Given this list of marker genes MSMO1, EBP, HSD17B7, GGPS1, SREBF1, HMGCR, DHCR7, LBR, LSS, DHCR24, PLPP6, ARV1, TM7SF2, MVK, NSDHL, IDI1, CYP51A1, SC5D, SREBF2, IDI2, SQLE, PMVK (phosphomevalonate kinase), HMGCS1, FDPS, FDFT1, ACAT2, MVD, here is a description of the gene set: Reactome Pathway: Cholesterol biosynthesis Cholesterol is synthesized de novo from acetyl CoA, which is transformed in an initial sequence of 15 reactions into lanosterol. The synthesis of cholesterol from lanosterol is classically said to follow either of two major routes, one in which reduction of the double bond at position 24 in the isooctyl side chain is the final step (cholesterol synthesis via desmosterol, the Bloch pathway and one in which this reduction is the first step (cholesterol biosynthesis via lathosterol, the Kandutsch-Russell (KR) pathway (Kandutsch & Russell 1960).<p>More recent tracer studies in intact mice and human and mouse cell lines support a revised view of the physiological roles of these two pathways. These studies indicate that the Bloch pathway is the predominant one in most tissues, notably testes and adrenal gland, and is constitutive. Little flux through the complete KR pathway was found in any tissue. Instead, Mitsche et al. observed a modified form of the pathway, in which delta(24)-sterol reductase (DHCR24) reduced zymosterol, a Bloch pathway intermediate, to zymostenol, a KR intermediate, which was then metabolized via the last three steps of the KR pathway to form cholesterol. Usage of this pathway was observed in skin, preputial glands and brain. Here, these reactions are grouped into two pathways. “Zymostenol biosynthesis via lathosterol” contains the initial nine steps of the KR pathway that now appear to play a minor role in cholesterol biosynthesis. “Cholesterol biosynthesis from zymosterol (modified KR pathway)” contains the reaction that generates ZYMSTNL and the three KR reactions that convert it to cholesterol.<p>The 7-dehydrocholesterol produced by the modified KR pathway in skin is the starting point for the synthesis of D vitamins. Defects in several of the enzymes involved in this process are associated with human disease and have provided useful insights into the regulatory roles of cholesterol and its synthetic intermediates in human development. part of: Metabolism of steroids species: Homo sapiens